The following is a description of a gene set: studied in species Homo sapiens Human Gene Set: HP_CORONARY_ARTERY_STENOSIS Coronary artery stenosis Abnormal narrowing of the coronary artery., and this is the list of marker genes: PNPLA2, ELN (NCBI Gene Id 2006), YY1AP1, DYRK1B, ABCA1, MLXIPL